The following is a description of a gene set: Histone deacetylase 7 (HDAC7) is highly expressed in CD4(+)/CD8(+) thymocytes and functions as a signal-dependent repressor of gene transcription during T-cell development. In this study, we expressed HDAC7 mutant proteins in a T-cell line and use DNA microarrays to identify transcriptional targets of HDAC7 in T cells. The changes in gene expression levels were compared to differential gene expression profiles associated with positive and negative thymic selection. This analysis reveals that HDAC7 regulates an extensive set of genes that are differentially expressed during both positive and negative thymic selection. Many of these genes play important functional roles in thymic selection, primarily via modulating the coupling between antigen receptor engagement and downstream signaling events. Consistent with the model that HDAC7 may play an important role in both positive and negative thymic selection, the expression of distinct HDAC7 mutants or the abrogation of HDAC7 expression can either enhance or inhibit the signal-dependent differentiation of a CD4(+)/CD8(+) cell line. Genes up-regulated in DO11.10 cells (hybridoma) by expression of transciptionally activating form of HDAC7 and down-regulated by its transcriptionally repressing form. Mouse Gene Set: KASLER_HDAC7_TARGETS_1_UP species: Mus musculus from publication Kasler HG, Verdin E (PMID 17470548), and this is the list of marker genes: Dapk3, Cuta, Gpaa1, Ankrd39, Mrps2, Irf4, B4galt3, St3gal5, Bcor, Farsa, 1110002E22Rik, Tesk1, Dusp10, Poc1a, Poldip2, Lrp10, Sbf1, Gpr146, Maco1, Abcb9, Slc35a4, Nhej1, Tmem41a, Rhobtb2, Rftn1, Elk3, Rara, Pin1, Vars1, Pik3cd, 2610318N02Rik, Henmt1, Maz, Akap12, Lta, Cap1, Hc, Capn7, Rbfa, Ddx21, Cpeb1, Usp19, Rab1b, C2cd2l, Itk, Lsp1, Tmem273, Cdh17, Rita1, Ugcg, Mrps11 (NCBI Gene Id 97380), Fuca2, Tg, Akap1, Hacd3, Asb2, Sgsm3, Rnf187, Mier2, Ubxn6, Unc119b, Tsc22d1, Pcyt1a, Filip1l, Mfge8, Mepce, Clstn1, Lef1, Zfp707, Cd96, Tmub1, Capn3, Ssr2, Mtss1, Gpat4, Bcl2, Pex6, Sema4d, Hip1r, Galc, Pkp3, Runx1, Dgkz, Rassf3, Grb2, Iqcf5, Npl, Wsb2, Chst2, Ankrd9, Ikzf1, Itgb3, Cnnm3 (NCBI Gene Id 94218), Pdcd1, Dad1, Phka1, Ncoa3, Atp2a2, Timmdc1, Ldlrad4, Sit1, Tdp1, Gm2a, Erp29, Gpr65, Lats2, Pglyrp2, Abhd8, Gpn2, Trib1, Osbpl3 (oxysterol binding protein-like 3), Ahsg, Hspbp1, Zbtb7b, Pbx3, Tomm40, 2510009E07Rik, Peds1, Arhgap27, Eno3, Dnmt3a, Aen, Stat5a, Pick1, Zap70, Endou, Tec, Macroh2a1, Cytip, Fbxw11, Ctu2, Rasal1, Sesn3 (sestrin 3), Pla2g6, Wdr82, Pias4 (protein inhibitor of activated STAT 4), Steap3 (NCBI Gene Id 68428), Shkbp1, Bcl6, Tmem37, Fbxl6, U2af2, Bves, Rps6ka1, Gltp, Smap2, Ddx19b, Tgfb1 (transforming growth factor, beta 1), Asb8, Bpgm, Fryl, Bmp4, B4galt1, Arhgef2 (NCBI Gene Id 99482), Nrgn, Pigt, Cyfip2, Cd6, Dffb (DNA fragmentation factor, beta subunit), Cd28, Pknox1, Hmg20b, Trim35, Fasn, Ttc39b, Lman2, Ap1m1, Slco3a1 (solute carrier organic anion transporter family, member 3a1), Ppp5c, Cdk2, Marchf3, Ankrd23 (ankyrin repeat domain 23), Ptger4, Cemip2, Dusp2, Nr4a1, Stat3, Fgd2, Ubash3b, Ide, Cd247, Mul1, Chst10, Hdac5, Ccr4, Syvn1, P2rx7, Shisa5, Clptm1, Asb6, Ncoa2, Ccr8, Cyp20a1